Given this list of marker genes UCHL1, CLEC12B, IGSF1, DKK4, LGALS3, ESR2, LY6H, PXDN, ADH7, DKKL1, DKK1, IL18BP, LY6S, CCL5, AGTR2, WFIKKN2 (NCBI Gene Id 124857), DUT, LYPD6, LRPAP1, PCSK9 (proprotein convertase subtilisin/kexin type 9), IL36RN, LY6G6D (NCBI Gene Id 58530), WFIKKN1, SLURP2, IGFBP2, FST, DKK3, IL1RN, LY6E, LYNX1, LYPD1, LILRB4, DKK2, FKBP1A, here is a description of the gene set: Binds to and modulates the activity of a signaling receptor. Human Gene Set: GOMF_SIGNALING_RECEPTOR_INHIBITOR_ACTIVITY species: Homo sapiens